Given this list of marker genes TCN2, ABCD4, LRP2, LMBRD1, LDLRAP1, TCN1, CD320, ABCC1, here is a description of the gene set: The steps of transport of cobalamins (RCbl) from the enterocyte to the cells in which it will function as a cofactor, together with its reuptake in the renal tubule, are annotated here. While methylcobalamin is the predominant cobalamin in the blood, other cobalamins including cyanocobalamin and adenosylcobalamin are also present and the proteins involved in these processes accommodate all of them. This broad specificity is indicated by annotating R-cob(III)alamin (RCbl - ) as the cargo in all of these processes. studied in species Homo sapiens Reactome Pathway: Transport of RCbl within the body part of: Cobalamin (Cbl, vitamin B12) transport and metabolism